Given this list of marker genes MYH14, RHOB, MYL6, MYH11, RHOC, PAK1, LIMK2, CFL1, PPP1R12A, RHOA, PPP1R12B, MYL12B, MYH10, LIMK1, MYH9, ROCK2, MYL9, ROCK1, PPP1CB, here is a description of the gene set: RHO GTPases Activate ROCKs studied in species Homo sapiens Human Gene Set: REACTOME_RHO_GTPASES_ACTIVATE_ROCKS